The following is a description of a gene set: from publication Cui A, Huang T, Li S, Ma A, Pérez JL, Sander C, Keskin DB, Wu CJ, Fraenkel E, Hacohen N (PMID 38057668) Cytokines mediate cell-cell communication in the immune system and represent important therapeutic targets. A myriad of studies have highlighted their central role in immune function, yet we lack a global view of the cellular responses of each immune cell type to each cytokine. To address this gap, the authors created the Immune Dictionary, a compendium of single-cell transcriptomic profiles of more than 17 immune cell types in response to each of 86 cytokines (>1,400 cytokine-cell type combinations) in mouse lymph nodes in vivo. A cytokine-centric view of the dictionary revealed that most cytokines induce highly cell-type-specific responses. For example, the inflammatory cytokine interleukin-1β induces distinct gene programmes in almost every cell type. A cell-type-centric view of the dictionary identified more than 66 cytokine-driven cellular polarization states across immune cell types, including previously uncharacterized states such as an interleukin-18-induced polyfunctional natural killer cell state. Mouse Gene Set: CUI_CDC2_LIF_RESPONSE_UP Genes positively differentially expressed in cell type: cDC2 (conventional dendritic cell type 2) upon treatment with cytokine: LIF in mouse lymph nodes in vivo. species: Mus musculus, and this is the list of marker genes: Casp6, Vcam1, Il21r, Ifitm2, Ms4a6d, Eif4g1, Gpr171, Ndufs3, Gpr35, Mrps7, Manf, Gadd45g, Mafb, Tspo (translocator protein), Lamp2, Cdk2ap2, Wfdc17, Timm10b, Nr4a3, Creld2, Psmb5, Ccnd3 (cyclin D3), Psmb8 (NCBI Gene Id 16913), Rab3il1, Sdc3 (syndecan 3), Il4ra, Dnajb11, Smdt1, Rbm3, Bzw2, Ldha, Lmnb1, Pdia6, Orai1, Fabp5, Ptpn1, Cd53, Bcl3, Vars1, Arap2, Eif6, Dok2, Septin3, Cdkn2d, Tgfbi, Mrps24, Lsm12, Mrpl20, Tmem106a, Mt1, Flot1 (flotillin 1), Atp5mc1, Ikzf1, C1qc, Cfp, Tspan13, Ly6a, Cyp7b1, Ssr2, Spint1, Ddx39a, Mrpl52, Vav1, Srgn, Cd38, Rnh1, Id2, Gpr146, Scimp, Mvp, Calr, Eif5a, Xbp1, Cfl1, Ifitm1, Eps8, Olfm1, Zfand3, Dab2, Lyn, Fyn, Pkm, Ninj1, Clec4n, Socs3, Rnf149, Cyrib, Dad1, Hsd17b10, Lgmn, Fkbp5, Ddx54, Cst7, Prelid1